The following is a description of a gene set: Any process that modulates the frequency, rate, or extent of myeloid leukocyte differentiation. Mouse Gene Set: GOBP_REGULATION_OF_MYELOID_LEUKOCYTE_DIFFERENTIATION studied in species Mus musculus, and this is the list of marker genes: Tjp2, Fgfr3, Rbp1, Tmem64, Pilrb1, Clec2i, Esrra, Trem2, Zbtb46 (NCBI Gene Id 72147), Tmem178, Pik3r1, Gata2, Cdk6, Apc, Ccl3, Hcls1, Il12b, Csf1, Ptpn2, Jun, Tob2, Tnfrsf11b, Ifnb1, Tnfrsf11a, Lif, Cebpb (CCAAT/enhancer binding protein beta), Fstl3, Tnfaip6, Cd101, Lef1, Cartpt, Id2, Trib1, Ccl9, Tfe3, Pou4f1, Pias3, Pla2g3, Adipoq, Iapp, Lrrc17, Pira12, Myc, Nedd9, Tescl, Slc9b2, Dcstamp, Bmyc, Ceacam1, Zfp36l1, Clec2g, Fshr, Rara, Lyn, Qki, Lilrb4b, Hoxa7, Cd74, Mir223, Gpr137b, Itgb3, Csf1r, Apcs, Pou4f2, Klf10, Evi2b, Ctnnb1, Rptor, Prkca, Nme2, Cldn18, Erfe, Gfi1b, Rb1 (NCBI Gene Id 19645), Hax1, Ltf, Fes (feline sarcoma oncogene), Sfrp1, Pira1, Runx1, Ccr1, Ror2, Prxl2a (NCBI Gene Id 70564), Clec2d, Ubash3b, Creb1, Gpr137, Acin1 (NCBI Gene Id 97920), Fbn1, Ccr1l1, Stat5a, Evi2, Zfpm1, Car2, Inpp5d, Nf1, Il34, Tnfsf11, Cul4a, Mafb, Eeig1, Gpr55, Ripk1, Prdm16, Hsf1, Ninj1, Tgfb1, Foxp1, Thoc5 (THO complex 5), Tyrobp, Adam8, Ctnnbip1, C1qc, Kitl, Fadd, Gnas, Traf6, Tal1, Fshb, Ppp3ca, Fos, Ocstamp, Il23a, Il5, Il4, Notch2, Ppargc1b, Rassf2, Asxl2, Nme1, Mtor, Ifng, Fbxw7, Cd4, Ccl5, Gsk3b, Zbtb7a, Ndfip1, Tesc, Casp8, Ikzf1, Inpp4b, Mitf, Il17a, Tnf, Itgam, Gpr68, Il20, Il3, Dlk1, Tcta, Lilrb4a